Given this list of marker genes CHMP7 (NCBI Gene Id 91782), TCEA1, NELFCD, MVB12B, BANF1, TPR, NUP153, NELFE, XPO1, VPS37C, NUP58, TAF9, NUP88, POLR2A, GTF2A2, FURIN (furin, paired basic amino acid cleaving enzyme), TAF10, RANBP1, NUP210, NUP107, RCC1, SEC13, TAF5, POLR2D, MVB12A, NUP205, VPS37A, GTF2E1, CCR5, NUP42, NMT1, NELFB, CCNH, POM121C, CHMP2B, HMGA1, AAAS, TAF13 (NCBI Gene Id 6884), KPNA1, NCBP2, POLR2L, POLR2E, NUP43, TSG101, RNMT, NEDD4L, VPS37B (NCBI Gene Id 79720), VPS37D, GTF2F1, CCNK (NCBI Gene Id 8812), NUP155, ELOA, CCNT1, POLR2B, RNGTT, RANBP2, UBA52, TAF7, NUP160, TAF2, GTF2H5, UBB, NUP188, CD4, TAF6, TAF12, POLR2I, TAF4B, TBP, PDCD6IP, NDC1, ERCC2, CDK9, CXCR4, CHMP2A, POLR2J, NMT2, UBC, RANGAP1, POM121 (NCBI Gene Id 9883), VPS4B, POLR2K, POLR2H, TAF15, NUP133, TAF4, CTDP1, FEN1, NELFA, PPIA, VTA1, CHMP6, GTF2F2, UBAP1, RAE1, CHMP4A, SUPT4H1, LIG1, NUP54, SEH1L, CCNT2, POLR2F, SUPT16H, TAF1, ERCC3, RPS27A, NUP62, GTF2E2, XRCC6, NUP37, GTF2H4, TAF9B, SSRP1, NUP214, GTF2H2, NUP35, GTF2H1, NUP85, TAF1L, SUPT5H, NCBP1, GTF2H3, VPS28, CHMP3, ELOB, ELOA2, XRCC4, CHMP4B, TAF11, NUP50, RAN, POLR2C, CDK7, TAF3, ELL, TAF7L, CHMP5, VPS4A, PSIP1, XRCC5, LIG4, CHMP4C, ELOC, NUP98, NUP93, MNAT1, POLR2G, GTF2A1, GTF2B, here is a description of the gene set: studied in species Homo sapiens Human Gene Set: REACTOME_HIV_LIFE_CYCLE HIV Life Cycle